Given this list of marker genes TMEM231, SIDT2, CD72, CNNM4, MAP3K12, ZNF610, IFI44, DOP1B, CELF1, IL7, FLNB, ZBTB7B, RAB8B, TASOR (transcription activation suppressor), IFI16, BRAF, TAF7, CD1C, JADE2, PCYOX1L, AKAP13, CHD7, CEP126, DDX39B, SLC38A11, ARMH3, SETDB1 (SET domain bifurcated histone lysine methyltransferase 1), ARHGAP24, RASGRP2, IL4R, CDK5R1, CD81, PTBP3, RCSD1, TRAPPC9, TBC1D5, LTB, GIT2, TMEM164, MEPCE, NUDCD3, TSC22D3, CASD1, BBS10, NPC1, EGLN2, DDR1, EPG5, ANO9, RNF43, STXBP5, PLEKHF2, SORL1, PLEKHG7, MED15, LRRC56, PTP4A2, GTDC1, FBXW4P1, CCNY, FMO1, SIK3, MX2, MNDA, PARVG, ERICH1, GNA13, SDCBP, COLGALT1, IFNGR2, MARCHF1, PRKACB, NUMA1, KHDRBS2, VPS41, PI4K2A, ATPAF2, PTPRCAP, SERPINB9P1, PARP14, DENND11, STAT5A, SLC6A6, WDR77, TFEB (transcription factor EB), C7orf57, SERPINA7, SATB1, UVRAG, ARL10, FCRLA, TOM1, CR2, STIM2, EIF4G3, RIPOR1, RNF144B, SNTB1, DHRS9, VPS13C, CRYBG1, ZC3HAV1, ZBED2, RNF216, CLASRP, DMD, MANBA, LRRC37B, BACH2, ZSCAN18, LYSMD2, DZIP3, GFOD2, FCHSD2, GGA1, AP1G2, TERF2, WWP2, CCDC93, RAB11FIP1, INTS2, CEP135, TRMT2B, TBC1D10A, B4GALT5, LAT2, RABEP1, MADD, RNF130, TVP23A, CNPY3, ABCG1, SPECC1L, WRNIP1, NEIL1, MAX, MEF2A, HCK, CRBN, PLEKHG1, LMBR1L, ERICH3, GRB2, KDM1B, BBX, USF1, HERC4, CD1D, EPB41, ST3GAL3, LPGAT1, HOMER1, FAM81A, RBMS1, MYO1E, PFDN5, MAPRE2, CCR6, IRS2 (insulin receptor substrate 2), SERTAD2, TRIM22, DEAF1, DCLK2, PDLIM2, AMFR, R3HDM4, SNORD116-1, GSAP, ZDHHC2, BTG1, MOB3B, SF1, GABBR1, ATRNL1, ZFYVE27, CD79B, KLF16, LARS1, CHN2, VHL, KLF4, DTX4, IFNGR1, C11orf21, CIAO2A, PTPN6, ELK4, ACTB, SEMA4F, HEATR5B, ZNF28, RYK, MIDEAS, BLOC1S2, RUFY1, PTPN12, ID3, ITGAM (integrin subunit alpha M), here is a description of the gene set: from publication Miyazawa M, Takashima A (PMID 22974541) Human Gene Set: GSE20727_CTRL_VS_H2O2_TREATED_DC_UP studied in species Homo sapiens Genes up-regulated in dendritic cells: untreated versus hydrogen peroxide. Identification of ROS induced genes on dendritic cells Dendritic cells were incubated for 15 min with or without a ROS inhibitor (DPI), washed extensively and incubated for 30 min with a chemical allergen (DNFB), hydrogen peroxide, and vehicle alone in HBSS containing DPI or vehicle. After washed extensively, the samples were post-incubated for 5.5 h with DNFB, hydrogen peroxide, or vehicle in complete culture medium containing DPI or vehicle.